The following is a description of a gene set: Human Gene Set: HP_PROPTOSIS studied in species Homo sapiens An eye that is protruding anterior to the plane of the face to a greater extent than is typical. Proptosis, and this is the list of marker genes: TWIST1, PTCH1, TSHR, B3GALT6, DHCR7, PPP2CA, XYLT1, RNU12, AXIN1, AKT1, CSGALNACT1, TERT, SNRPN, NXN, ASPM, IPO8, FGF9, ELMO2, BPNT2, FZD2, VAC14, CKAP2L, SLX4, PIGG, BRCA2, PDGFRB, RAF1, NSD2, P3H1, IL11RA, TGDS, CREBBP, SMO, ROR2, GATA4, NBAS, WDR4 (NCBI Gene Id 55896), FANCL, PLAGL1, IFT81, CYP27A1 (cytochrome P450 family 27 subfamily A member 1), COL3A1, PCLO, FLNB, TBCK, MAN2B1, DVL3, POLA1, SMARCE1, RAD51C, TCTN3, COL11A1, IRF4, TNFRSF11A, BAP1, INPPL1, TGFBR2, KAT6A, SIX3 (SIX homeobox 3), SCN4A, HACE1, GJA5, AUTS2, GATA5, ASXL1, PTPN11, SMARCB1, TCF12, RRAS, PRUNE1, DVL1, SOS1, CPLX1, TGFB1, GDF1, LRP4 (NCBI Gene Id 4038), KCNQ1OT1, PLK4, ZMPSTE24, HNRNPK, ALPL, ITCH, KCNQ1, NDE1, SOS2, TRAF7, CDK5RAP2, CLP1, MMP2, SMAD3, RIT1, KDM5A, NRAS, HYMAI, PRTN3, COL11A2, ALK, PLOD3, MYOD1, RASA2, ERCC4, LEMD2, THRB (thyroid hormone receptor beta), MITF, BRCA1, FGFR3, MAFB (MAF bZIP transcription factor B), ERI1, SLC25A24, FLI1, RAC3, SPRED2, RRAS2, BGN (NCBI Gene Id 633), OSTM1, ADAMTS10, SH3BP2, ATXN3, NKX2-6, PARS2, EP300, CTLA4, LETM1, FANCM, CHST3, ZIC2, MRAS, PLCB3 (NCBI Gene Id 5331), GNPTAB, NFIX, FGFR2, BRAF, DYNC1I2, FAM20C, AP3B2, SPECC1L, PTPN22, VANGL2, PSMB8, P4HB, FLT4, FANCA, XRCC2, SPTBN1, FGFR1, LIN28B, DBR1, PIGB, PKDCC, RTTN, SLC39A14, CTBP1, SIN3A, UBE2T, LMNA, FANCB (FA complementation group B), FGFRL1, NAA10, HERC1, SHPK, TBX1, FIG4, SOST, PHOX2B, FOCAD, NF2, SERPINH1, IGF2, PDGFB, NKX2-5, FN1, WASF1, TGFBR1, PSAT1, SMS, LTBP1, B3GAT3, FANCD2, CDON, SEC24D, CDH11, TBC1D24 (NCBI Gene Id 57465), POLR3A, EFEMP2, SKIC3, ZIC1, COL2A1, FANCG, B4GALT7, SUFU, LMO1, ASXL2, HLA-DPA1, KRAS, FANCC, RNU4ATAC, ERF, FLNA, MAF, WNT5A, PEPD, CBL, FBXO11, SHH (sonic hedgehog signaling molecule), POLR3GL, RFWD3, CDKN1C, APC, NEDD4L, SOX9, ZNF699, MUSK, FOXC1, INSR, JAG1, HECTD4, PPIB, COG1, TAF1, LZTR1, CACNA1C, FANCE, SLC29A3 (NCBI Gene Id 8072), POR, ASXL3, HLA-DPB1, RSPRY1, CANT1, CRELD1, MYD88, NF1, ANTXR1 (NCBI Gene Id 84168), MTX2, EXTL3, MAD2L2, SETBP1, NELFA, GATA6, RAD51, DDR2, ABCA12, FBN1, PIK3CA, RECQL4, HSPG2, PHGDH, CDC45, ZFPM2, CRIPT, CRTAP, CITED2, BRIP1, MYCN, DPYSL5, AFF4, LRP2 (NCBI Gene Id 4036), TMEM53, NOTCH3, ALG9, FANCI, PTH1R, NIPBL, FANCF, KDR, SH3PXD2B, MTHFR, COL1A1, WBP4, NLRP3, PALB2, SKI, TGFB3, POLD1, WDR26 (NCBI Gene Id 80232), COG4, STAG2, AHDC1, CTSK, ESCO2, SLC39A13, EBF3, KCNJ6, NAA60, BMP4, BANF1